The following is a description of a gene set: studied in species Homo sapiens Human Gene Set: GOBP_ECTODERM_DEVELOPMENT The process whose specific outcome is the progression of the ectoderm over time, from its formation to the mature structure. In animal embryos, the ectoderm is the outer germ layer of the embryo, formed during gastrulation., and this is the list of marker genes: FZD7, BMPR1A, EDA2R, MIR145, ZBTB7B, ELF5, TPT1, L3MBTL2, GRHL3, ZBTB17, ITGA6, CTNNB1, SMURF1, EPB41L5, LHX1, STX2, KRT6B, SHH, NF2, ETS2, AMER2, ITGAM, VPS52, VAX2